The following is a description of a gene set: species: Mus musculus Mouse Gene Set: REACTOME_DNA_DAMAGE_TELOMERE_STRESS_INDUCED_SENESCENCE DNA Damage/Telomere Stress Induced Senescence, and this is the list of marker genes: Pot1a, H2bc24, H4c12, H2ab1, H2ac24, Kat5, Asf1a, H2bc21, H4c18, H2ac18, H1f1, Hmga1b, Ubn1, H4c8, H2bc4, H2ac19, H2ac22, H2ac23, H2bc9, Terf2ip, H2ac10, H2ab2, H1f2, Ccna2, Hmga2, H2bc23, H2ab3, Terf2, H3f4, H4c11, Rad50, H2bc26, H2bc12, Hira, H2bc14, Ccne2, Hmga1, H4c2 (H4 clustered histone 2), Ep400, H4c1, H4c14 (NCBI Gene Id 97122), Mre11a, H2ac11, Cabin1, Acd, H2bc15, H4c6, H2ac15, H2ac8, H2ax, H2bc13, H2ac12, Trp53, Cdkn1b, H2ac20, H4c4, H2ac6, H2ac7, H2aj, H2ac4 (NCBI Gene Id 319172), H4c16, H4c17, H2bc22, H1f5, H2bc8, H2bc7, Atm, H2bc3, Nbn, Ccne1, H4c3, Cdk2, H2bc6, H2az2, H1f0, Ccna1, Cdkn1c, Rb1, Cdkn1a, Lmnb1, H1f4, H2ac13, Terf1, H2bc1, H2bc11, H4c9